The following is a description of a gene set: The compaction of chromatin located adjacent to the CENP-A rich centromere 'central core' and characterized by methylation of histone H3K9, into heterochromatin, resulting in the repression of transcription at pericentric DNA. Mouse Gene Set: GOBP_PERICENTRIC_HETEROCHROMATIN_FORMATION studied in species Mus musculus, and this is the list of marker genes: H3f3b, Hells, Dicer1, Sirt6, Cenpv, H3f3a